The following is a description of a gene set: Underdevelopment of frontal sinus. species: Homo sapiens Hypoplastic frontal sinuses Human Gene Set: HP_HYPOPLASTIC_FRONTAL_SINUSES, and this is the list of marker genes: FLNA, AGA, COL11A1, RUNX2, SFRP4, ALX3, TRIM37